Given this list of marker genes PSMB4, IFIT1 (NCBI Gene Id 8374), TNFSF10, SDCBP, PSMC6, YWHAZ, MAL (mal, T cell differentiation protein), SLC25A5, PTGS1, SSR1, OAT, CD9, NUP153, CD47, UBXN4, HMGB2, CSE1L, CCNE1, KDELR2, HNRNPU, NASP, MRPL3, RAF1, PTS, TPM4, H2AZ1, NUP205, PRKDC, ACP1, DPM1, SLC35B1, COX7B, ATP1B3, SUMO1, LDHA, MELK, PRSS8, PLSCR1 (NCBI Gene Id 5359), TM4SF1, LRPPRC, YBX1, HMGN3, RAD21, PRKCD, BTG3, ATP13A3, EFR3A (EFR3 homolog A), CKS1B, ATP5F1B, ATP5PB, PSMA2, PRKCI, SUMO2, PSMA3, SDHB, COPB2, CYCS, B2M, DDX39A, IARS1, PARP1, RFC4, UBA1, NMI, HERPUD1, SPP1, PSMB2, CKAP5, ZNF146, ADAR, CKS2, CSNK2B, GNAS, SLC35A2, MAP2K1, RALY, DDX5, COPS5, MBTPS1, CAPG, TMED10, MEST, MAPRE1, CSTB, CFI, SRSF4, SRSF9, EPRS1, NDUFS1, POLR2K (NCBI Gene Id 5440), TARS1, SRPK1, THAP11, ARF4, TUBBP1, UBE2V2, HNRNPD, GLO1, RHEBP1, GPI, COX6A1, SNRPB2, HNRNPM, MDH1, CDKN3, FH (fumarate hydratase), IFI44, CBX1, SNRPD3, TCEA1, SPCS2, IFI30, NDUFV2, ATP5F1C, RANBP1, HMGN1, SPINT2, CTNNA1, here is a description of the gene set: from publication Ouellet V, Provencher DM, Maugard CM, Le Page C, Ren F, Lussier C, Novak J, Ge B, Hudson TJ, Tonin PN, Mes-Masson AM (PMID 15940270) Genes up-regulated in epithelial ovarian cancer (EOC) biopsies: invasive (TOV) vs low malignant potential (LMP) tumors. Tumors of low malignant potential (LMP) represent 20% of epithelial ovarian cancers (EOCs) and are associated with a better prognosis than the invasive tumors (TOV). Defining the relationship between LMPs and TOVs remains an important goal towards understanding the molecular pathways that contribute to prognosis, as well as providing molecular markers, for these EOCs. To this end, DNA microarray analyses were performed either in a primary culture or a tumor tissue model system and selected candidate genes showing a distinctive expression profile between LMPs and TOVs were identified using a class prediction approach based on three statistical methods of analysis. Both model systems appear relevant as candidate genes identified by either model allowed the proper reclassification of samples as either LMPs or TOVs. Selected candidate genes (CAS, CCNE1, LGALS8, ITGbeta3, ATP1B1, FLIP, KRT7 and KRT19) were validated by real-time quantitative PCR analysis and show differential expression between LMPs and TOVs. Immunohistochemistry analyses showed that the two tumor classes were distinguishable by their expression of CAS, TNFR1A, FLIP, CKS1 and CCNE1. These results define signature patterns for gene expression of LMPs and TOVs and identify gene candidates that warrant further study to deepen our understanding of the biology of EOC. studied in species Homo sapiens Human Gene Set: OUELLET_OVARIAN_CANCER_INVASIVE_VS_LMP_UP